Given this list of marker genes PDE3B, AKT2, here is a description of the gene set: PKB and PDK1 are activated via membrane-bound PIP3. Activated PDK1 phosphorylates PKB, which in turn phosphorylates PDE3B. The latter hydrolyses cAMP to 5'AMP, depleting cAMP pools. part of: PI3K Cascade species: Homo sapiens Reactome Pathway: PKB-mediated events